The following is a description of a gene set: from publication Chen Y, Wang X (PMID 31504780) Mouse Gene Set: MIR_6932_3P studied in species Mus musculus Genes predicted to be targets of miRBase v22 microRNA mmu_miR_6932_3p in miRDB v6.0 with MirTarget v4 prediction scores > 80 (high confidence targets)., and this is the list of marker genes: EU599041, Zfp54, Rspo2, Bicral, Tmem64, Hdac9, Fndc7, Zfp384, Trpm3, Piwil2, Ccr4, Tpm1, Arx, Cyyr1, Rab11fip2, Slc8a1, Rnf128, Magea9, Btn2a2, Pcsk5, Cnot2, Usp39, Fam168b, Samd8, Acss2, Braf, Ogfrl1, Ash1l, Aktip, Afdn, Clk2, Wnt3a, D630045J12Rik, Usp29, Rpe, Gvin3, Slc4a4, Cp (NCBI Gene Id 51906), Psmf1, Otub2, Dcx, Bcl2l2, Calr3, Eif5a2, Wapl, Rictor, Pter, Oaz2, Pitpnb, Tasor, Nde1, Slc28a2b, Slit2, Pramel27, Mpzl2, Tfap2a, Kdm7a, Ubash3b, Klf4 (NCBI Gene Id 269540), Carf, Acvr2b, Sec23ip, Wrn, Styx, Zfp521, Sla, Carmil1, Vgll3, Copg1, Pik3ca, Zwint, Nlrc4, Zmat4, Slc28a2, Rad21, Znfx1, Pex13, Itpkb, Plekha8, Neurod4, Usp54, Acvr2a, Hspa13, Cdk12, Nom1, Blzf1, Dll4, Ercc5, Lcorl, Tbc1d32, Kbtbd6, Ube2d3, Rpap1, Xirp1, Tomm7, P2ry10, Lama5, Zfp936, Vps37c, Nipal3, Zfp148, Syt14, Fam168a (family with sequence similarity 168, member A), Ankrd39, Iho1, Zcchc2, Mtcp1, Gfra1, Il1b, Selenop, Gabra1, Zswim6, Zfp963, Gtsf1, Cpsf7, Nufip2, Styxl1, Snai2, Emilin3, Clec7a, Kcne2, Ctdspl, Nfat5, Map3k1